Given this list of marker genes RNF150, BRI3, PLAGL2, MS4A6A, SNRNP48, CXCR4, SURF1, TMEM86A, FER, JADE2, CLK1, BRD8, STX16, FBXL4, DOP1B, KLF6, PIGV, DYNLT1, SLC46A3, ZFYVE1, RNPEP, KIF3A, REPS2, PHAF1, POR, PTBP2, FNBP1, ATOSA, SLC35F5, PRR18, PLCG2, IFITM3, NLRC5, CALHM6, ANKRD33B, PIANP, FAM76B, IRF8, AGO4, MCTP1, DBNDD2, CD93, FAM107B, TPCN1, FCGR1A, RASGEF1B, TIFA, PYGL, DENND5A, C5orf34, PLD2, FRRS1, ABHD12, ZC3H12D, CYFIP2, TRAF3, ATP8A1 (NCBI Gene Id 10396), SLC28A2, C5AR1, BSDC1, RRAS, PAXBP1, ARRDC3, PTPN18, FCHO2, PARP14, DBP, GDF15, MFGE8 (milk fat globule EGF and factor V/VIII domain containing), MYLIP (NCBI Gene Id 29116), BNIP3L, ANAPC15, TMEM35B, PPOX (NCBI Gene Id 7440), SLC37A2, CPEB2, APPL2, NFAT5, PIK3AP1, N4BP2L1, ITGAL, THBD, PPT1, FUCA1, ANTXR2, GIT2, SIDT2, KANSL2, HELZ2, CYBB, GSTM3 (NCBI Gene Id 2947), SUPT3H, NIPAL3, APOE, SLC15A4, DEPDC7, CDC25B, KHDC4, EPSTI1, DDX60, FLCN, S1PR1, IFIT1B, SASH1, FAM3C, SAP130, FNIP2, EIF5A2, BASP1, AMPD3, WWP1, ZMYND11, ARHGAP18, RANBP10, RABAC1, RELL1, CAB39, WDR6, IFIT2, LCORL, DTX3L, ZNF329, ADIPOR1, SNX27, GDPD5, NINJ1, CAMK1, SMG1 (SMG1 nonsense mediated mRNA decay associated PI3K related kinase), NBEAL1, WDFY4, TCTN3, BMP2, RNF149, CXCL10, NEDD4L, LMO2, WASHC1, PLEKHM3, YWHAH, SPSB2, SMIM14, CCDC12, NOTCH1, ABCC3, GPR137B, PIK3CG, TCP11L2, PMP22, RNF144B, EP300, ATP8B4, AP1S2, IQCB1, CEP295, PGAP6, ZKSCAN3, PCK2 (NCBI Gene Id 5106), NCKAP1L, PDLIM2, EZH1, TGFBR2, PELI2, GTPBP2, MSRB1, HTRA2, ZBTB4, RPS6KA5, CD302, IGFBP4, FGD4, IL7R, CCRL2, CAMK1D, KLHL6, TLR2, AGAP1, EYA3, LRATD2, ALOX5AP, TLR7, CYP4V2, IQGAP2, MPP1, MCL1, XYLT2, MAP3K8, ZNF653, TRMT112, CCNT2, SLC40A1, H2AC25, B4GALT6, ANKRD44, PTK2B, CEP192, TM4SF5, PSTPIP2, CARD19, ARAP3, SFSWAP, here is a description of the gene set: from publication Frankenberger M, Hofer TP, Marei A, Dayyani F, Schewe S, Strasser C, Aldraihim A, Stanzel F, Lang R, Hoffmann R, Prazeres da Costa O, Buch T, Ziegler-Heitbrock L (PMID 22531920) Genes down-regulated in CD16+ monocytes versus dendritic cells. species: Homo sapiens Human Gene Set: GSE34515_CD16_POS_MONOCYTE_VS_DC_DN In this study gene expression of human blood classical monocytes (CD14++CD16-), CD16 positive monocytes (consisting of non-classical CD14+16++ and intermediate CD14++CD16+ monocytes) and CD1c+ CD19- dendritic cells from healthy subjects were investigated.